The following is a description of a gene set: Covalent attachment of the ubiquitin-like protein UFM1 to another protein. studied in species Homo sapiens Human Gene Set: GOBP_PROTEIN_UFMYLATION, and this is the list of marker genes: UFM1 (NCBI Gene Id 51569), CDK5RAP3 (NCBI Gene Id 92989), UBA5, DDRGK1, UFC1, UFSP1, UFL1